The following is a description of a gene set: Human Gene Set: VERHAAK_AML_WITH_NPM1_MUTATED_DN Genes down-regulated in acute myeloid leukemia (AML) patients with mutated NPM1. Mutations in nucleophosmin NPM1 are the most frequent acquired molecular abnormalities in acute myeloid leukemia (AML). We determined the NPM1 mutation status in a clinically and molecularly well-characterized patient cohort of 275 patients with newly diagnosed AML by denaturing high-performance liquid chromatography (dHPLC). We show that NPM1 mutations are significantly underrepresented in patients younger than 35 years. NPM1 mutations positively correlate with AML with high white blood cell counts, normal karyotypes, and fms-like tyrosine kinase-3 gene (FLT3) internal tandem duplication (ITD) mutations. NPM1 mutations associate inversely with the occurrence of CCAAT/enhancer-binding protein-alpha (CEBPA) and NRAS mutations. With respect to gene expression profiling, we show that AML cases with an NPM1 mutation cluster in specific subtypes of AML with previously established gene expression signatures, are highly associated with a homeobox gene-specific expression signature, and can be predicted with high accuracy. We demonstrate that patients with intermediate cytogenetic risk AML without FLT3 ITD mutations but with NPM1 mutations have a significantly better overall survival (OS) and event-free survival (EFS) than those without NPM1 mutations. Finally, in multivariable analysis NPM1 mutations express independent favorable prognostic value with regard to OS, EFS, and disease-free survival (DFS). studied in species Homo sapiens from publication Verhaak RG, Goudswaard CS, van Putten W, Bijl MA, Sanders MA, Hugens W, Uitterlinden AG, Erpelinck CA, Delwel R, Löwenberg B, Valk PJ (PMID 16109776), and this is the list of marker genes: H2BC8, TRAF5, ICAM4, LHFPL2 (NCBI Gene Id 285713), EMP1, MMP9, PRAME, FOXO1, NPR3 (NCBI Gene Id 79614), NEDD4, XYLT1, DCHS1, CD7, MEF2C, CD48, EPS8, IL5RA, MPL, CST7, DNTT, SPON1, MSLN, HBG1, EHD3, ATP9A, MST1, RAP2A, PRODH, TGFBI, MPO, AK4, LPAR6 (lysophosphatidic acid receptor 6), ALAS2, GNG7, TMOD1, RRAGD, GMPR, STAP1, VEGFA, SERPING1, TNFRSF21 (TNF receptor superfamily member 21), TMEM158, EGFL7, PROM1, MDFIC, ARHGEF12, GJA1, PTPRCAP, RGS1, TFPI, THSD7A, MTMR11, HPGDS, RBPMS, LTF, GNAI1, NRXN2, PMAIP1, MN1, SNRPN, OTULINL, ST18, CD38, PRKD3, CCR2, ITGA6, TRDC, MREG, TCN1, GATM, TOX, DHRS3, CD1C, YPEL1, PDE3B, SSBP2, FHL1, LMO4, SNCA, TRIB2, ENDOD1, S100P, NCAM1, TKTL1, CSF3R, CHI3L1, MXRA7, SPIB, GPM6B, TMEM204, BAALC, IFI44L, CD3D, SPRY1, TSPAN7, PTGER4, RPS6KA2, SERPINF1, PALM, ZHX2, ABLIM1, SYNGR1, SH3BP4, MX1, JUP, ASS1, MYH11, GATA3, NBL1, FAM171A1, AGTPBP1, FLNB, ABCB1, HLA-DPA1, MAN1A1, EZR, HPGD, IFITM1, TACSTD2, MEG3, PTPRM, SORL1, BAIAP3, SCRN1, RHOBTB3, IGFBP7, CYTL1, H1-0, CAVIN1, PAM, ARAP2, CACNA2D2, VLDLR, ADIPOR1, DEPTOR, F2RL1, BANK1 (NCBI Gene Id 55024), PTGIR, NIBAN1, GSN, B4GALT6, SMAGP, TM6SF1, DACH1, ITM2C, HLA-DQA1, PCDHGC3, VPREB1, DLK1, CLEC10A (NCBI Gene Id 10462), GPA33, MECOM, FGF13, KRT1, ADCY3, GALC, IFI44, SPTBN1, PRTN3, GYPC, ITM2A, RETN, C2CD2, FGFR1, MEF2A, TSPOAP1, SERINC5, NT5E, ARHGEF17, STK32B, HGF, UGCG, HSPB1, CAV1, FCMR, LRP3, ZAP70, CEACAM4, HLA-DPB1, TPSAB1, TSPAN13, POU4F1, OPTN, HSPG2, CD2, DPYSL2, FZD2, ROBO1, SLC38A1, CEACAM6, TRPM4, CLDN15, RUNX1T1 (NCBI Gene Id 862), WASF1, APP, BPGM, TCF3, P2RX5, ANXA8, IFI16, CD69, ERG, CD200, BPI, FCER1A, BLNK, CYP2E1, HOPX, TRBC2, LDLRAD4, MLLT3, CLIP3, XAGE1B, TRH, PLXND1, EVL, MEST, PXDN, LAMC1 (laminin subunit gamma 1), MS4A3, DSE, TGFB1I1, POLE, SPARC, ACSL4, LCN2, PALM2AKAP2, SCCPDH, ISG20, FZD6, ALDH2, CD34, LAMP5, KIT, CHKA, CSGALNACT1, RUNX3, ELANE, CCND2, CIAO3, PDE4B, CD19, ADISSP, SIDT1, CLEC5A, RAMP1, SERPINE2, GPSM2, CIITA, PPP1R16B